The following is a description of a gene set: BACKGROUND: Live attenuated influenza vaccine (LAIV) and trivalent inactivated influenza vaccine (TIV) are effective for prevention of influenza virus infection in children, but the mechanisms associated with protection are not well defined. METHODS: We analyzed the differences in B-cell responses and transcriptional profiles in children aged 6 months to 14 years immunized with these 2 vaccines. RESULTS: LAIV elicited a significant increase in naive, memory, and transitional B cells on day 30 after vaccination, whereas TIV elicited an increased number of plasmablasts on day 7. Antibody titers against the 3 vaccine strains (H1N1, H3N2, and B) were significantly higher in the TIV group and correlated with number of antibody-secreting cells. Both vaccines induced overexpression of interferon (IFN)-signaling genes but with different kinetics. TIV induced expression of IFN genes on day 1 after vaccination in all age groups, and LAIV induced expression of IFN genes on day 7 after vaccination but only in children < 5 years old. IFN-related genes overexpressed in both vaccinated groups correlated with H3N2 antibody titers. CONCLUSIONS: These results suggest that LAIV and TIV induced significantly different B-cell responses in vaccinated children. Early induction of IFN appears to be important for development of antibody responses. Genes down-regulated in blood 1d vs 0d in children (0.5-14y) after exposure to Fluzone, time point 1D. Comment: ~80% of cohort were white, ~50/50 Female:male Human Gene Set: CAO_BLOOD_FLUZONE_AGE_05_14YO_1DY_DN studied in species Homo sapiens from publication Cao RG, Suarez NM, Obermoser G, Lopez SM, Flano E, Mertz SE, Albrecht RA, García-Sastre A, Mejias A, Xu H, Qin H, Blankenship D, Palucka K, Pascual V, Ramilo O (PMID 24495909), and this is the list of marker genes: TGM3, PGM3, ORM1, PHOSPHO2, CACNA2D2, FAM209B